The following is a description of a gene set: species: Homo sapiens from publication Sakai Y, Honda M, Fujinaga H, Tatsumi I, Mizukoshi E, Nakamoto Y, Kaneko S (PMID 19074895) Selected genes up-regulated in peripheral blood monocytes (PBMC) of patients with hepatocellular carcinoma (HCC) compared to those with chronic hepatitis. Human Gene Set: SAKAI_CHRONIC_HEPATITIS_VS_LIVER_CANCER_UP Hepatocellular carcinoma (HCC) is frequently associated with infiltrating mononuclear inflammatory cells. We performed laser capture microdissection of HCC-infiltrating and noncancerous liver-infiltrating mononuclear inflammatory cells in patients with chronic hepatitis C (CH-C) and examined gene expression profiles. HCC-infiltrating mononuclear inflammatory cells had an expression profile distinct from noncancerous liver-infiltrating mononuclear inflammatory cells; they differed with regard to genes involved in biological processes, such as antigen presentation, ubiquitin-proteasomal proteolysis, and responses to hypoxia and oxidative stress. Immunohistochemical analysis and gene expression databases suggested that the up-regulated genes involved macrophages and Th1 and Th2 CD4 cells. We next examined the gene expression profile of peripheral blood mononuclear cells (PBMC) obtained from CH-C patients with or without HCC. The expression profiles of PBMCs from patients with HCC differed significantly from those of patients without HCC (P < 0.0005). Many of the up-regulated genes in HCC-infiltrating mononuclear inflammatory cells were also differentially expressed by PBMCs of HCC patients. Analysis of the commonly up-regulated or down-regulated genes in HCC-infiltrating mononuclear inflammatory cells and PBMCs of HCC patients showed networks of nucleophosmin, SMAD3, and proliferating cell nuclear antigen that are involved with redox status, the cell cycle, and the proteasome system, along with immunologic genes, suggesting regulation of anticancer immunity. Thus, exploring the gene expression profile of PBMCs may be a surrogate approach for the assessment of local HCC-infiltrating mononuclear inflammatory cells., and this is the list of marker genes: HNRNPA1, ITPR1, TRAF6, CASP4, RANBP2, CENPB, GLRX2, AXIN2, TXN, HIF1A, USP14, CBX3, NCK1, CMC4 (NCBI Gene Id 100272147), SRSF1, RNMT, CASP9, MYC, SMNDC1, CUL5, MICA, HLA-DOA, CAT, UBE3A, USP33, CANX, ST13, GSTT2, UBE2L3, FBXO5, ATF6, TLR2, UPF3A, CASP1, TNPO1, CUL2 (NCBI Gene Id 8453), ATF2, UBE2D1, PPP3R1, JAK1, PCNA, APBB1, ESPL1, CUL1, MPHOSPH6, HSP90AA1, CSE1L, UBE2D2, PIGB, HAT1, UBE2A, CENPC, LAMTOR3, MAP3K5, USP8, TCP1, ATF6B, HSPA4, HSF2, CCR1, USP7, NAE1, MICB, SOD2, PRDX3, HNRNPDL, CTSS, UBE2V2, HNRNPK, GPX3, KPNA4, YME1L1, TACC1, PTPRC, PIK3CA, RNASE4, HLA-DRA, UBE2N, HNRNPU, APAF1, HNRNPR, UBE2D3